Given this list of marker genes Kpna4, Kpna3, Kpna2, Kpna7, Snupn, Kpna6, Kpnb1, Mybbp1a, Kpna1 (NCBI Gene Id 16646), Kpna2rt, here is a description of the gene set: Mouse Gene Set: GOCC_NLS_DEPENDENT_PROTEIN_NUCLEAR_IMPORT_COMPLEX A dimer consisting of an alpha and a beta-subunit that imports proteins with an NLS into the nucleus through a nuclear pore. species: Mus musculus